Given this list of marker genes ZNF706, TRAPPC6A, NF2, FHIP1A, INTS8, DHPS, BCL6, YPEL5, AKAP7, FMC1, SORL1, IFNAR2, EXOC3, NCAPD2, LIAS, PLAU, DHX16, JAML, FEZ1, TNF, BCL3, MRPS6, CABLES1, TRIM45, ARHGAP9, CST7, NFATC1, ENC1, LAGE3, NKX2-2, SMYD4, LINC02843, SERPINC1, CAPS2, PGBD2, MAST3, KLK14, ZBTB14, YWHAEP7 (tyrosine 3-monooxygenase/tryptophan 5-monooxygenase activation protein epsilon pseudogene 7), IGSF1, RAB7B, DDB2, ZBTB44-DT, CEACAM7, CLCN5, THEMIS2, NFATC2, MICAL2, RAC2, CCDC63, MYLK, PRKAG2-AS1, EPS8L2, MICAL3, TNFRSF10A-DT, KDSR, OPN5, FES, PLXNB2, MBTPS1, SAP30L-AS1, SLC39A9, LTB, BCL7A, BCKDK, ANKH, TCF12-DT, ASAP2 (ArfGAP with SH3 domain, ankyrin repeat and PH domain 2), TRIM39, PDE4A, ASL, UTF1, ERMARD, PPP3CA, SNX29, CHTF8, NAV2-AS5, REPS2, DHRS9, SHB, ZBTB46, DNAJB6, CTSD, SMUG1, ARHGAP26, ZNF264, NUDT13 (NCBI Gene Id 51055), MAGED1, EQTN (equatorin), FKBP9, SHOX, MS4A14, LRRC20, SFRP4, ZSWIM7, IDS, XPR1, HEXB, MIPEP, LY86, RAB4B, ZDHHC11, KIT, SMG9, ZCRB1, CHPF2, MEN1, TRAPPC12, ARL4C, EPRS1, TRAF3IP3, GINS3, C14orf28, PRPF40B, TP53TG3HP, LRRC56, C17orf99, UTS2B, STARD9, AHI1-DT, PECAM1, TSHZ1, RAP2A, DISP1, PVR, PIH1D1, CENPK, EHBP1, ARHGEF6, SURF1, SIPA1L1, NAV2, CCDC42, GPX7, ARIH2, APRG1, MMP13, MROH7, CCL1 (C-C motif chemokine ligand 1, NCBI Gene Id 6346), CDO1, FBN1, NYNRIN, CEACAM21, LMO2, LINC00926, ARL6IP4, ACTMAP, NEK11 (NCBI Gene Id 79858), UBXN6, RELB, CYP27A1, INPP5A, BAP1, STX7, C5, SLC25A25-AS1, GANAB, HLX, NDUFA11, NISCH, KLHL41, MAPK14, DOCK11, CXADR, RIMS3, DUSP22, SSH1, VASP, DALRD3, CAMKK1, SYTL1, ABHD4, ZBED2, CCDC28A, IRS2, LINC02363, WWC3, COX7A1, APLP1, BAIAP2-DT, LINC01565, PYCARD, IL10RA (NCBI Gene Id 3587), REEP4, CAV2, HAGH, LRWD1, REDIC1, ZNF23, SLCO3A1, ACKR2, CDK14, CYP2R1, TIFAB, STK11, LINC02577 (long intergenic non-protein coding RNA 2577), here is a description of the gene set: studied in species Homo sapiens Interaction of hematopoietic progenitors with the thymic stromal microenvironment induces them to proliferate, adopt the T cell fate, and asymmetrically diverge into multiple T lineages. Progenitors at various developmental stages are stratified among different regions of the thymus, implying that the corresponding microenvironments differ from one another, and provide unique sets of signals to progenitors migrating between them. The nature of these differences remains undefined. Here we use novel physical and computational approaches to characterize these stromal subregions, distinguishing gene expression in microdissected tissues from that of their lymphoid constituents. Using this approach, we comprehensively map gene expression in functionally distinct stromal microenvironments, and identify clusters of genes that define each region. Quite unexpectedly, we find that the central cortex lacks distinctive features of its own, and instead appears to function by sequestering unique microenvironments found at the cortical extremities, and modulating the relative proximity of progenitors moving between them. Human Gene Set: GSE18281_CORTEX_VS_MEDULLA_THYMUS_DN from publication Griffith AV, Fallahi M, Nakase H, Gosink M, Young B, Petrie HT (PMID 20064453) Genes down-regulated in thymus: whole cortex versus whole medulla.